Given this list of marker genes Bcat1, Inpp5d, Ranbp17, Phf24, Hinfp, Cep295, Gm26983, Apela, Rnf11, Plxdc2, Lrrc49, Toe1, Mif4gd, Tnpo3, Tent2, Dag1, Ifnar1, Uqcc1 (NCBI Gene Id 80446), Tomm7, Chn1, Nap1l4, Scap, Gm4128, Mrps9, C920006O11Rik, Resf1, Cox7a2l, Timm13, Tent4b, Tmem129, Acyp1, Msrb1, Zfp568, Efcab12, Tfdp2, Cep72, Zfp280d (zinc finger protein 280D), Heatr1 (NCBI Gene Id 94251), Nap1l1, Tacc3, Arhgap26, Slc12a6, Txnip, Zmym4, Tma7, Fkbp1b, Prkn, Slc1a5, Slco3a1, Fign, Hsd17b11, Aktip, Ndufs6, Gm15441, Slc35c2, Avpi1, Mutyh, Tinagl1, Manea, Nwd2 (NCBI Gene Id 73214), Atrx, Lamtor4, Cemip, Dynlt1b (dynein light chain Tctex-type 1B), Lmtk3, Map4k1, Atg101, Lpcat3, Gm16103, Pdlim7, Plaur, Spry4, Utp23, Dvl2, Ccdc51, Znrf1 (zinc and ring finger 1), Eif3k, Gm21985, Rgs16, Zer1, Pacrg, Gtf2i, Polr1c, Mrpl9, Ndufa3, Dtl, Osbpl7, Oscar, Cit, Dynlt1a, Mfsd3, Prodh2, Slc35b1, Itpa, Yipf3, Cdk2ap1rt, Rxfp3, Rbpj, Cnot1, Snx10, Mir301, Ccdc126, Zzz3, Mix23, Mtcl1, Pfkfb4, here is a description of the gene set: studied in species Mus musculus Mouse Gene Set: ZFP273_TARGET_GENES from publication Yevshin I, Sharipov R, Kolmykov S, Kondrakhin Y, Kolpakov F (PMID 30445619)